Given this list of marker genes Ifi206, Isg15, Ifi27l2a, Bst2, Rtp4, Rnf213, here is a description of the gene set: Cytokines mediate cell-cell communication in the immune system and represent important therapeutic targets. A myriad of studies have highlighted their central role in immune function, yet we lack a global view of the cellular responses of each immune cell type to each cytokine. To address this gap, the authors created the Immune Dictionary, a compendium of single-cell transcriptomic profiles of more than 17 immune cell types in response to each of 86 cytokines (>1,400 cytokine-cell type combinations) in mouse lymph nodes in vivo. A cytokine-centric view of the dictionary revealed that most cytokines induce highly cell-type-specific responses. For example, the inflammatory cytokine interleukin-1β induces distinct gene programmes in almost every cell type. A cell-type-centric view of the dictionary identified more than 66 cytokine-driven cellular polarization states across immune cell types, including previously uncharacterized states such as an interleukin-18-induced polyfunctional natural killer cell state. Genes positively differentially expressed in cell type: CD8+ T cell upon treatment with cytokine: CD30L in mouse lymph nodes in vivo. from publication Cui A, Huang T, Li S, Ma A, Pérez JL, Sander C, Keskin DB, Wu CJ, Fraenkel E, Hacohen N (PMID 38057668) studied in species Mus musculus Mouse Gene Set: CUI_T_CELL_CD8_CD30L_RESPONSE_UP